The following is a description of a gene set: studied in species Homo sapiens part of: RHO GTPase cycle This pathway catalogues RHOQ (also known as TC10) guanine nucleotide exchange factors (GEFs), GTPase activator proteins (GAPs), and RHOQ effectors. No GDP dissociation inhibitors (GDIs) have been shown to interact with RHOQ. Two GDIs, ARHGDIA (also known as Rho-GDI alpha) and ARHGDIB (also known as D4-GDI), were specifically shown not to interact with RHOQ. RHOQ, together with RHOJ (TCL), belongs to the CDC42 subfamily of RHO GTPases, with the three family members sharing 65-85% of homology. RHOQ is highly activated on exocytosing vesicles and recycling endosomes. RHOQ GTPase activity is necessary for fusion of vesicles with the plasma membrane. RHOQ is required for insulin-stimulated glucose uptake and is involved in insulin signaling in adipocytes. While some studies reported RHOQ involvement in neurite outgrowth and regulation of membrane addition during axon formation, other studies failed to identify RHOQ as a regulator of neurite outgrowth. Reactome Pathway: RHOQ GTPase cycle, and this is the list of marker genes: VAMP3, LAMTOR1, ARHGAP35, RHOQ, CDC42EP3, ARHGAP1, WWP2, CAV1, CDC42, STOM, JUP, CDC42EP1, ITSN1, SLC1A5, DIAPH3, ARHGAP21, MPP7, CDC42EP4, DLC1, SLC4A7, CDC42BPB, CFTR, VANGL1, SCRIB, SYDE1, PREX1, ARL13B, FNBP1, SNAP23, IQGAP1, ARHGAP26, GJA1, SRGAP2, ARHGEF9, IQGAP3, ARHGAP33, WASL, GOPC, ARHGAP17, TFRC, PLEKHG3, CDC42BPA, TRIP10, CDC42EP2, DEPDC1B, PAK1, ARHGAP5, ARHGEF7, CPNE8, GFOD1, GIT2, PAK2, OBSCN (NCBI Gene Id 84033), OPHN1, STEAP3, ARHGAP32, RAB7A, PAK4, GIT1